The following is a description of a gene set: studied in species Homo sapiens A state characterized by a feeling of weakness and loss of strength leading to a generalized weakness of the body. Human Gene Set: HP_ASTHENIA Asthenia, and this is the list of marker genes: SERPINA6, PRORP, PIGA, AIP, CRELD1, LBR, ALAS2, MEFV, GPR101, SPTAN1, HNRNPA2B1, DGUOK, PLEKHM1, NSDHL, MTHFD1, MAN2B1